Given this list of marker genes Fstl1, Bst2, Lamp1, Myh11, Lgals1, Ifi27, Rpl37, Hsp90aa1, Apoc3, Eln, Krt10, Egr1, Gas6, Rbp7, Bgn, Cavin3, Fcgrt, Ptov1, Ogn, Oaf, Mgst3, C1qb, Hexa, Wfdc1, Uqcr10 (ubiquinol-cytochrome c reductase, complex III subunit X), Hspa1a, Mtch1, Plac9 (NCBI Gene Id 353370), Ppp1r14a, Postn, Ctsl, Dcn (NCBI Gene Id 13179), Eif4a1, Zfp36, Hbb-bs, Chd2, Cst3, Acta1, Csf1r, Col3a1, Rtn4, Pltp, F13a1, Col1a2, Dstn, Igfbp7, Rpgr, Ppic, Rps28, Pfn1, Klf4, Col15a1, Dnaja1, Cited2, Igfbp3, Jund, Timp2, Tppp3, Dpt, Hspa8, Lgals7, Lum, Egf, Cd83, Tgfbi, Rps29, Dynll1, Sat1, Dapl1, Serpinh1, Fabp4, Prss23, Dusp1, Umod, Fam25a, Sostdc1, Rpl38, Fam111a, Cnn1 (NCBI Gene Id 12797), Hes1, Fbn1, Itm2a, Col6a2, Fn1, Map1lc3a, Tpm1, H2-Ea, Hspb1, Tmem176b, Dnajb1, Btg1, Slc12a1, Selenow, Col18a1, Ccdc80, Col1a1, Ccn3, Atf3, Fcna, Jun, Dmpk, Cav1, Serpinf1 (NCBI Gene Id 20317), Krt1, Fabp1, Htra1, mt-Atp6, Mfap2, Rnd3 (Rho family GTPase 3), Tuba1a, Cebpb (CCAAT/enhancer binding protein beta), Myl9, Atp5me, Ywhah, Ndufa4l2, Ly6d, Rps21, Sptssa, Ltc4s, Gsn, Ybx1, Lox, Serf2, Crip1, Krt14, Hsph1, Col4a1, Fhl1, Hba-a1, Gadd45g, Alb, Flna, Cpz, Pam (NCBI Gene Id 227401), Id4, H2-Ab1, Actg2, Igfbp6, Ptms, Tagln, Csrp1, Ccl24, Id3, Krtdap, Tpm2, Sparc, Mrc1, Itgb5, H2-Aa, Rps17, Frzb, Ccl21a, Des, mt-Nd1, Apoc1, Rpl39, Pcolce, Fos, Mfap5, Prdx1, here is a description of the gene set: Aging causes a functional decline in tissues throughout the body that may be delayed by caloric restriction (CR). However, the cellular profiles and signatures of aging, as well as those ameliorated by CR, remain unclear. Here, we built comprehensive single-cell and single-nucleus transcriptomic atlases across various rat tissues undergoing aging and CR. CR attenuated aging-related changes in cell type composition, gene expression, and core transcriptional regulatory networks. Immune cells were increased during aging, and CR favorably reversed the aging-disturbed immune ecosystem. Computational prediction revealed that the abnormal cell-cell communication patterns observed during aging, including the excessive proinflammatory ligand-receptor interplay, were reversed by CR. Our work provides multi-tissue single-cell transcriptional landscapes associated with aging and CR in a mammal, enhances our understanding of the robustness of CR as a geroprotective intervention, and uncovers how metabolic intervention can act upon the immune system to modify the process of aging. from publication Ma S, Sun S, Geng L, Song M, Wang W, Ye Y, Ji Q, Zou Z, Wang S, He X, Li W, Esteban CR, Long X, Guo G, Chan P, Zhou Q, Belmonte JCI, Zhang W, Qu J, Liu GH (PMID 32109414) species: Rattus norvegicus Mouse Gene Set: MA_RAT_AGING_DN Genes down-regulated across multiple cell types from nine tissues during rat aging.